The following is a description of a gene set: To investigate the early host response triggered by three different strains of Trypanosoma cruzi at a local infection site, changes in host gene expression were monitored in a murine intradermal infection model using Affymetrix oligonucleotide arrays. Robust induction of IFN-stimulated genes (ISGs) was observed in excised skin 24 hours post-infection where the level of ISG induction was parasite strain-dependent with the least virulent strain triggering a muted IFN response. Infection of mice immunodepleted of IFNγ-producing cells or infection of IFNγ-deficient mice had minimal impact on the IFN response generated in T. cruzi infected mice. In contrast, infection of mice lacking the type I IFN receptor demonstrated that type I IFNs are largely responsible for the IFN response generated at the site of infection. These data highlight type I IFNs as important components of the innate immune response to T. cruzi the site of inoculation and their role in shaping the early transcriptional response to this pathogen. We used microarrays to detail the local host transcriptional response to intradermal T. cruzi infection in WT mice and mice depleted of NK cells, or deficient in IFN-gamma or type I IFN responses. Additionally we compared the local host-transcriptional response generated to infection with 3 different strains of Trypanosoma cruzi (Y, Brazil, and G). Genes up-regulated in skin from BALB/c mice after injection of: control versus Trypanosoma cruzi (strain Y). studied in species Homo sapiens from publication Chessler AD, Unnikrishnan M, Bei AK, Daily JP, Burleigh BA (PMID 19201883) Human Gene Set: GSE13522_CTRL_VS_T_CRUZI_Y_STRAIN_INF_SKIN_BALBC_MOUSE_UP, and this is the list of marker genes: NT5C, SRM, TSN, GRAMD2A, MGMT, PACSIN2, FHL2, OGFRL1, PRMT5, PGD, NDUFAF1, HMGN3, SMYD2, TRAPPC10, WT1-AS, BAX, ICAM1, PKM, MRPS27 (NCBI Gene Id 64948), SPAST, TACSTD2, LRRC8C, MAD1L1, SERPINC1, NIPSNAP3A, STX6, ADGRF2P, CLNS1A, MPI, TPM1, DDIT4, MYO5B, MRPS33 (NCBI Gene Id 65515), ENO1, MLST8, CENPF, DTX3, PDCD2, LDHA (lactate dehydrogenase A), NME1, SOWAHC, ZC3H12C, PAK1IP1 (NCBI Gene Id 55003), THEM4 (thioesterase superfamily member 4), NDFIP2, SLC2A1, EIF3D, PMPCB, YARS2, SLC39A12 (NCBI Gene Id 221074), HLCS, SLC30A4, FAM118B, FBXO6, TSR2, POMP, CFAP144P1, PSMC4, SELENON, KRTAP6-3, RPS26, PHF5A, TXNRD1, ETFA, STXBP6, RPL14, SARNP, ABHD16B, BSG, NOMO1, KLC2, OPN3, F8, MRTO4, MIR499A, CNTN1, PCDHB12, RPS8, TSGA10 (NCBI Gene Id 80705), TPD52, CEP126, MRPL57, SLC4A11, BAG1, FZD7, CPT1C, MCUB, PTPN1, ZFAND1, IL18, MPC1, TMCO1, ITGA1, TPI1, LAT2, ZMAT2, PNLDC1, ERRFI1, C1D, EGLN1, RPS19BP1, KCNC2, HOOK2, GABRP, HNF4G, PCMT1, GNA12, MYH8, PLXNA3, LRRC59, CIMAP1D, METTL13, NAPSA, CCS (NCBI Gene Id 9973), RSU1, CABLES2 (Cdk5 and Abl enzyme substrate 2), SCN2A, MESD, ERH, ZSWIM7, TOMM40, ARL9, POLR3K, AK4, GLUL, ERI3, EIF4B, TBC1D7, SSR2, CYLC1, SCAP, MRPS18A, NGDN, GLIPR2, PTMS, SURF4, TM2D2, RS1